Given this list of marker genes DAGLB, DAGLA, ABHD12, MGLL, ABHD6, here is a description of the gene set: Diacylglycerol (DAG) is an important source of arachidonic acid, a signalling molecule and the precursor of the prostaglandins. In human platelet almost all the DAG produced from phosphatidylinositol degradation contains arachidonate. DAG is hydrolysed by DAG lipase to 2-arachidonylglycerol (2-AG) which is further hydrolysed by monoacylglycerol lipase. 2-AG is an agonist of cannabinoid receptor 1. studied in species Homo sapiens Reactome Pathway: Arachidonate production from DAG part of: Effects of PIP2 hydrolysis